Given this list of marker genes Id4, Nr4a1, Map3k14, Rasl11b, Hbegf, Egr3, Il6 (NCBI Gene Id 16193), Csrnp1, Junb, Gadd45b, Ier5, Slc20a1, Gadd45g, Fbln2, Smad7, Hes1, Spsb1, Serpine1, Nuak2, Lif, Klf10, Ptgs2, Fgf18, Wnt9a, Cdk5r1, Snai1, Egr2, Spata13, Bhlhe40, Ier3, Id1, Id2 (NCBI Gene Id 97802), Zmiz1, here is a description of the gene set: Mouse Gene Set: PLASARI_TGFB1_TARGETS_1HR_UP Transforming growth factor beta (TGF-beta) and platelet-derived growth factor A (PDGFAlpha) play a central role in tissue morphogenesis and repair, but their interplay remain poorly understood. The nuclear factor I C (NFI-C) transcription factor has been implicated in TGF-beta signaling, extracellular matrix deposition, and skin appendage pathologies, but a potential role in skin morphogenesis or healing had not been assessed. To evaluate this possibility, we performed a global gene expression analysis in NFI-C(-/-) and wild-type embryonic primary murine fibroblasts. This indicated that NFI-C acts mostly to repress gene expression in response to TGF-beta1. Misregulated genes were prominently overrepresented by regulators of connective tissue inflammation and repair. In vivo skin healing revealed a faster inflammatory stage and wound closure in NFI-C(-/-) mice. Expression of PDGFA and PDGF-receptor alpha were increased in wounds of NFI-C(-/-) mice, explaining the early recruitment of macrophages and fibroblasts. Differentiation of fibroblasts to contractile myofibroblasts was also elevated, providing a rationale for faster wound closure. Taken together with the role of TGF-beta in myofibroblast differentiation, our results imply a central role of NFI-C in the interplay of the two signaling pathways and in regulation of the progression of tissue regeneration. from publication Plasari G, Calabrese A, Dusserre Y, Gronostajski RM, McNair A, Michalik L, Mermod N (PMID 19752192) studied in species Mus musculus Genes up-regulated in MEF cells (embryonic fibroblast) upon stimulation with TGFB1 for 1 h.